The following is a description of a gene set: Genes within amplicon 7p22 identified in a copy number alterations study of 191 breast tumor samples. A single cancer cell contains large numbers of genetic alterations that in combination create the malignant phenotype. However, whether amplified and mutated genes form functional and physical interaction networks that could explain the selection for cells with combined alterations is unknown. To investigate this issue, we characterized copy number alterations in 191 breast tumors using dense single nucleotide polymorphism arrays and identified genes with copy number gain organized into 30 amplicons. Amplicons were distributed unequally throughout the genome. Each amplicon had distinct enrichment pattern in pathways, networks, and molecular functions, but genes within individual amplicons did not form coherent functional units. Genes in amplicons included all major tumorigenic pathways and were highly enriched in breast cancer-causative genes. In contrast, genes with somatic mutations in breast cancer were distributed randomly over the genome, did not represent a functionally cohesive gene set, and were relatively less enriched in breast cancer marker genes. Mutated and gained genes did not show statistically significant overlap but were highly synergistic in populating key tumorigenic pathways including transforming growth factor beta, WNT, fibroblast growth factor, and PIP3 signaling. In general, mutated genes were more frequently upstream of gained genes in transcription regulation signaling than vice versa, suggesting that mutated genes are mainly regulators, whereas gained genes are mostly regulated. ESR1 was the major transcription factor regulating amplified but not mutated genes. Our results support the hypothesis that multiple genetic events, including copy number gains and somatic mutations, are necessary for establishing the malignant cell phenotype. studied in species Homo sapiens Human Gene Set: NIKOLSKY_BREAST_CANCER_7P22_AMPLICON from publication Nikolsky Y, Sviridov E, Yao J, Dosymbekov D, Ustyansky V, Kaznacheev V, Dezso Z, Mulvey L, Macconaill LE, Winckler W, Serebryiskaya T, Nikolskaya T, Polyak K (PMID 19010930), and this is the list of marker genes: CYP2W1, GPR146, CHST12, FOXK1, SUN1 (NCBI Gene Id 80226), BRAT1, TMEM184A, AP5Z1, GET4, FBXL18, LFNG, UNCX, TTYH3, ACTB, INTS1, PAPOLB, MRM2, EIF3B, MICALL2, GRIFIN, MAFK, GNA12, ADAP1, FAM20C, GPER1 (NCBI Gene Id 2852), SNX8, TNRC18, ZFAND2A, WIPI2, NUDT1, RADIL, PSMG3, MAD1L1, AMZ1, SLC29A4, IQCE, COX19, C7orf50